The following is a description of a gene set: from publication Amit I, Garber M, Chevrier N, Leite AP, Donner Y, Eisenhaure T, Guttman M, Grenier JK, Li W, Zuk O, Schubert LA, Birditt B, Shay T, Goren A, Zhang X, Smith Z, Deering R, McDonald RC, Cabili M, Bernstein BE, Rinn JL, Meissner A, Root DE, Hacohen N, Regev A (PMID 19729616) Genes up-regulated in comparison of control dendritic cells (DC) at 6 h versus those stimulated with LPS (TLR4 agonist) at 6 h. mouse primary BMDCs were stimulated with tlr ligands and gene expression changes were profiled on Affymetrix arrays Human Gene Set: GSE17721_CTRL_VS_LPS_6H_BMDC_UP studied in species Homo sapiens, and this is the list of marker genes: MAP3K3, MGST2, SMC3, OLA1, TMEM38B (NCBI Gene Id 55151), NAF1, RASSF3, TGFB3, GPX3, NUP35, FBF1, TGFBR1, CCNI (NCBI Gene Id 10983), PLXNB2, SPEG, SLC12A9, UBE4B, METTL18, KLHDC4, UPF3B, NAA60, ELOVL5, ZNF124, CUTA, NAGK, HHEX, GRN, NOXO1, MEPCE, PRPS2, SEMA6B, LAMTOR4, SKI, NAB1, SEC61B (SEC61 translocon subunit beta, NCBI Gene Id 10952), MRPS26, ING2, SEZ6L2 (NCBI Gene Id 26470), SEC24D, TMEM51, IVD, SOCS6, TPRKB, MRM1, FKBP7, NIT1, MAGED1, PLPP2, XPOT, SLC4A8, HACL1, CTNNBL1, COA7, ARRB1, GSDME, ALKBH4, PRKCH, LANCL1, DLG1, DNMT3B, R3HCC1, BSN, FAM98A, FLNA (filamin A), MATR3, SRPK3, RERE, ANKRD10, TARS2, FABP7, PON3, MPV17, NCBP1, SELENOP, HAND1, CDKN2C, SUPT20H, RPS14, MRPL4, ADRB2, MPDU1, TEX10, REEP1, HPGDS, TMEM179B, DNAJC9, RPL19, RBBP4, SLC39A11, LENEP, SMARCD2, PDXK (pyridoxal kinase), GAB3, STIL (STIL centriolar assembly protein), NCOR1 (nuclear receptor corepressor 1), DDT, APOC2, NCKIPSD, IFI30, CDKAL1, SNX14, GADD45G, CTR9, REV3L, MDP1, TXN2, TMED7, NME2, TSPAN14, ALDH3A2 (aldehyde dehydrogenase 3 family member A2), GCLM, HNRNPUL1, KPTN, RAC1, TNRC6B, CUEDC2, SELENBP1, PLEKHA1, CEP20, CAPN15, VAMP7 (NCBI Gene Id 6845), FLT3LG, EARS2, SGSH, DEPDC7 (DEP domain containing 7), HAUS3, EPS15, SHKBP1, SCP2, RPL28 (ribosomal protein L28), TPK1, MRPL36, APLF, TFB2M, MKNK2, ATG3, ZXDC, CETN2, FBXO25, RDH14 (retinol dehydrogenase 14), RBL2 (RB transcriptional corepressor like 2), UBXN1, MRPL42, GRIPAP1, TMEM14C, MAPK3, PDE8A, FBXL12, TRIM41, EEPD1, ERG28, RAB31, BNIP3L, PELI2, CLNS1A, AKR1C3 (aldo-keto reductase family 1 member C3), LAMA3, DTNBP1, HMOX1, TLN1 (talin 1), SC5D, RPS3, PHKA2, KAT7, NAA40, PLEKHG2, CDC23, FAF1, LDLRAP1, DIPK1B, NABP2, CRADD, SRP68, TMEM131L, RAMP1, PRKAB1, CEACAM21, SPC25, METTL8, BICD2, CMIP, ARMC7, QTRT1, EPRS1, PDCL, SAE1, DGCR6, XPA, MLLT10, CNOT9 (NCBI Gene Id 9125), RASAL3, GNAI3, TFEC, THOC1, TM9SF2, ITM2C, CD48, RPS8, PRKAG1, PHAX